The following is a description of a gene set: studied in species Mus musculus Any process that modulates the frequency, rate or extent of the chemical reactions and pathways involving lipoproteins, any conjugated, water-soluble protein in which the nonprotein group consists of a lipid or lipids. Mouse Gene Set: GOBP_REGULATION_OF_LIPOPROTEIN_METABOLIC_PROCESS, and this is the list of marker genes: Ulk1, Apod, Gba1, Atg13, Lipg, Pemt (NCBI Gene Id 18618), Hhatl, Pik3c3, Rab3gap1, Rabl3, Dbi, Dgat2, Itgb3, Rb1cc1, Atg101, Itgav, Svip, Rab3gap2, Angptl8, Lep